The following is a description of a gene set: Molecular approaches to understanding the functional circuitry of the nervous system promise new insights into the relationship between genes, brain and behaviour. The cellular diversity of the brain necessitates a cellular resolution approach towards understanding the functional genomics of the nervous system. We describe here an anatomically comprehensive digital atlas containing the expression patterns of approximately genes in the adult mouse brain. Data were generated using automated high-throughput procedures for in situ hybridization and data acquisition, and are publicly accessible online. Newly developed image-based informatics tools allow global genome-scale structural analysis and cross-correlation, as well as identification of regionally enriched genes. Unbiased fine-resolution analysis has identified highly specific cellular markers as well as extensive evidence of cellular heterogeneity not evident in classical neuroanatomical atlases. This highly standardized atlas provides an open, primary data resource for a wide variety of further studies concerning brain organization and function. Mouse Gene Set: LEIN_LOCALIZED_TO_DISTAL_AND_PROXIMAL_DENDRITES from publication Lein ES, Hawrylycz MJ, Ao N, Ayres M, Bensinger A, Bernard A, Boe AF, Boguski MS, Brockway KS, Byrnes EJ, Chen L, Chen L, Chen TM, Chin MC, Chong J, Crook BE, Czaplinska A, Dang CN, Datta S, Dee NR, Desaki AL, Desta T, Diep E, Dolbeare TA, Donelan MJ, Dong HW, Dougherty JG, Duncan BJ, Ebbert AJ, Eichele G, Estin LK, Faber C, Facer BA, Fields R, Fischer SR, Fliss TP, Frensley C, Gates SN, Glattfelder KJ, Halverson KR, Hart MR, Hohmann JG, Howell MP, Jeung DP, Johnson RA, Karr PT, Kawal R, Kidney JM, Knapik RH, Kuan CL, Lake JH, Laramee AR, Larsen KD, Lau C, Lemon TA, Liang AJ, Liu Y, Luong LT, Michaels J, Morgan JJ, Morgan RJ, Mortrud MT, Mosqueda NF, Ng LL, Ng R, Orta GJ, Overly CC, Pak TH, Parry SE, Pathak SD, Pearson OC, Puchalski RB, Riley ZL, Rockett HR, Rowland SA, Royall JJ, Ruiz MJ, Sarno NR, Schaffnit K, Shapovalova NV, Sivisay T, Slaughterbeck CR, Smith SC, Smith KA, Smith BI, Sodt AJ, Stewart NN, Stumpf KR, Sunkin SM, Sutram M, Tam A, Teemer CD, Thaller C, Thompson CL, Varnam LR, Visel A, Whitlock RM, Wohnoutka PE, Wolkey CK, Wong VY, Wood M, Yaylaoglu MB, Young RC, Youngstrom BL, Yuan XF, Zhang B, Zwingman TA, Jones AR (PMID 17151600) Transcripts showing subcellular localization to both distal and proximal dendrites in the adult mouse brain. species: Mus musculus, and this is the list of marker genes: Bok, Sbk1, Btbd3, Camk2a, Epb41l1, Lpar1, Kif5a, mt-Atp6, Adcy1, Dlg4, Itpr1, Rgs8, Psd, Hpcal4, Prxl2a, Sowaha, Ppp1r9b, Cpe